The following is a description of a gene set: part of: Signaling by NTRK3 (TRKC) Reactome Pathway: NTF3 activates NTRK3 signaling studied in species Homo sapiens NTRK3 (TRKC) is activated by binding to its ligand neurotrophin-3 (NTF3, also known as NT-3). Ligand binding induces dimerization of NTRK3 and trans-autophosphorylation of dimerized receptors on conserved tyrosine residues in the cytoplasmic tail. Autophosphorylated tyrosines serve as docking sites for binding of adaptor proteins that mediate downstream signaling., and this is the list of marker genes: NTRK3, NTF3